The following is a description of a gene set: species: Homo sapiens Pristanoyl-CoA, generated in the peroxisome by alpha-oxidation of dietary phytanic acid, is further catabolized by three cycles of peroxisomal beta-oxidation to yield 4,8-dimethylnonanoyl-CoA, acetyl-CoA and two molecules of propionyl-CoA. These molecules in turn are converted to carnitine conjugates, which can be transported to mitochondria. Reactome Pathway: Beta-oxidation of pristanoyl-CoA part of: Peroxisomal lipid metabolism, and this is the list of marker genes: SCP2, CRAT, ACOT8, ACOX3, ACOX2, CROT, HSD17B4, AMACR (NCBI Gene Id 23600), ACOXL